The following is a description of a gene set: Any process that stops, prevents or reduces the frequency, rate or extent of voltage-gated potassium channel activity. Mouse Gene Set: GOBP_NEGATIVE_REGULATION_OF_VOLTAGE_GATED_POTASSIUM_CHANNEL_ACTIVITY species: Mus musculus, and this is the list of marker genes: Grp, Kcne1, Kcne3, Kcnab1, Ank3, Cav1, Sumo1, Kcnrg, Kcne2, Kcnq1